The following is a description of a gene set: studied in species Homo sapiens Human Gene Set: GOBP_THYMIC_T_CELL_SELECTION The process of T cell selection that occurs in the thymus., and this is the list of marker genes: SPN (sialophorin), ITPKB, DOCK2, SRF, FOXN1, STK11, AIRE, GLI3, SHH, PTPN2, CD3D, ATG5 (NCBI Gene Id 9474), ZAP70, TOX, CD74, CD28, CD3E, CARD11, GATA3, PTPRC (protein tyrosine phosphatase receptor type C), CCR7, JAG2, NFATC3, CD3G